The following is a description of a gene set: Arachidonic acid is metabolized via three major enzymatic pathways: cyclooxygenase, lipoxygenase, and cytochrome P450. The cytochrome P450 pathway metabolites are oxygenated metabolites of arachidonic acid. part of: Cytochrome P450 - arranged by substrate type studied in species Homo sapiens Reactome Pathway: Eicosanoids, and this is the list of marker genes: PTGIS, CYP4F11, CYP4B1, CYP4F8, CYP4A11, TBXAS1, CYP4F12, CYP4A22, CYP8B1, CYP4F22, CYP4F2, CYP4F3